Given this list of marker genes HSPG2, DPP3 (dipeptidyl peptidase 3), CREB3L2, EP300, CDKN2A, ADCY2, TXNRD2, GPX5, PARN, HSPE1, CRTC2, RPL22, LONP1, ABCF2, NUP85, SEH1L, EP400, ASNS, ETS1, LMNA, PRDX5, RHEB, MUL1, DNAJB1, EXOSC6, SCMH1, ELOC, BMI1, H1-4 (H1.4 linker histone, cluster member), FKBP4, PSMA3, MAPK11, TLR4, RRAGB, H3C2, RPS27, LAMTOR4, RPL21 (NCBI Gene Id 6144), COX6B2, MAPK3, AKT1S1, H2BC9, KICS2, PSMB4, RPL37A, GNG13, RPLP2, MIOS, E2F2, GPX2, CDKN1B, PKN2, EPO, ASF1A, CREB1, COX7A2, TUBA3C, PECAM1, PRDX6, CREB3L1, WIPI1, SZT2 (NCBI Gene Id 79597), CAPNS2, H4C5, GML, H2BC12L, PPP2R1A, CSNK2B, TATDN2, EPAS1, RPS25, DNAJA2, TXN2, ATF6, NRIP1, CRYAB, COX7C, SUZ12, NUP214, GRB10, PDIA5, ATP6V1A, RPS12 (NCBI Gene Id 6206), GSTP1, H2AB1, HBA2, NOX5, CAPNS1, ME1, GNG12, SMARCD3, CAPN2, ANAPC16, RPS6KA1, ATP6V0C, CASTOR1, POT1, COX5A, H3-4, RPL38, RPL6 (NCBI Gene Id 6128, ribosomal protein L6), MTOR, NUP42, PSMA7, CDH5 (cadherin 5), RPL4, PPP2R2A, TERF2IP, CDC26, MTF1, FLT4, EGLN3, H4C16, MAPKAPK3, PHC1, MRE11, MLST8, EDEM1, DCTN6, ETS2, SIN3B, DEDD2, PTK2, RPL28, RB1, NFYA, EXOSC5, ACTR10 (actin related protein 10), CDK2, SKP1, MT1M, MAPK7, ANAPC10, CHD9, HSF1, CLEC1B, CDKN1A, RPL15, HSPB2, FABP1, RPL31, YIF1A, TUBB2A, ABL1, ADCY7, GPX3, ATF4, NOTCH1, H2BC10, H2BC12, ANAPC7, BTRC, FOS, ATP6V1G1, ST13, UBE2E1, PIK3R2, NFKBIA, DYNC1I2, COX7A2L, VEGFA, ZBTB17, ADRM1, ATP6V1B1, CHAC1, NUP62, PSMC1, PPARGC1A, HDGF, H3C6, RPS9, PPP2CA, BAG3, FBXL17, COX4I2, KPTN, NCOR2, CACNB2, RPL8, DNAJA4, APOB, ATP6V1C1, DYNC1I1, CALM1, TRPV4, PDGFA, PSMB5, TUBA1C, PTGES3, EXTL1, EGF, GSTA3, PSMA2, ABCC3 (NCBI Gene Id 8714), H2AJ, PSMB6, PRKAR2B, RPL12, LAMTOR3, PPP1R15A (NCBI Gene Id 23645), RPS27A, H2AC20, RPL18A (ribosomal protein L18a), H2BC13, RPL26, CABIN1, SNCB, CSRP1, PPP2R1B, ARFGAP1, STAT1, PRKAR2A, H2BC15, CBX4, RAMP2, PPARA, RPS6KA3, GNG5, EHMT1, MAPK8, HSPB1, H2BC5, PIK3CD, ATP6V1E2, SOD1, H2AC19, HSPA1B, SERPINH1, H2BC7, AR, DCTN5, ADCY3, UFD1, MT1H, ITGB3, ITGAV (NCBI Gene Id 7449), DNAJC3, HSBP1, TGS1, PRKCI, DDX11, NUP188, P4HB, MT1A, PREB, MAP2K3, E2F1, ANAPC11, H4C9, CALR, TNRC6B, CITED2, RPS17, TRIB3, MT-CO1, CCS, EXTL3, H4C3, DCTN4, RPL17, HSPD1, MYC, HSPA1L, STOML2, STAT3, WDR59, H3-3B, SSR1, NCOA1, IKBKE, RPA2, EGLN1, CDKN2B, CDC23, DCSTAMP (NCBI Gene Id 81501), GNB5, NUP98, BAG1, CCNE2, RPL39, COX6B1, RPS7, NCOR1, AGO1, SAMTOR (NCBI Gene Id 154743), FLCN, HIGD1A, DYNLL1, H1-3 (NCBI Gene Id 3007), GSK3A, EXOSC2, SRPRB, RPL13A, H3C11, TALDO1, MIR24-2, MAPK14, PIK3CA, PSMC2, CCNA1, HSPA8, CACNG7, HSPA13, SERP1, IKBKB, BLVRB, H3C1, RPL14, RPS14, GPX6, H1-0, ADCY9, HSPA9, ERO1A, HMOX2, CSNK2A2, XBP1, SKP2, RANBP2, EIF2S2, PSMC4, ACTR1A, PIK3CB, TBL1XR1, DEFA5, HSPH1, KDELR3, HSPA6, NPRL2, ANAPC5, NRF1, RPLP1, RPL10A, RPS5, MBTPS2, MAPK1, TINF2, CEBPB, CREBBP, COX7B, ABCG2, APOA1, CREB3L3, GNGT1, HSP90AB1, PDIA6, TNFRSF21, HSPA14, NDC1, P2RY2, NOS3, TUBB4A, ATF3, DYNLL2, NUP50, H2AC7, CDKN2C, BACH1, TBL1X, NFYB, ACD, PSMB7, PRDX1, CACNA1H, CAMK2A, PRR5, HSPA5, ITGA5, MAP2K7, TXNIP, H3C4, H4C4, H4C15, ANAPC15, HMOX1, RPL36, ATP6V1F, NBN (NCBI Gene Id 4683), PGR, GNGT2, AMER1, RPL24, PTK6, NUP160, CUL7, SRXN1, HMGA2 (high mobility group AT-hook 2), PSMD12, AKT2, TPR, RPS23, WTIP, HTRA2 (HtrA serine peptidase 2), H2AC14, PRKCD, KAT5, SIRT3, TUBB2B, NOX4, H3C14, DDIT3, BCL2, PRKAR1A, H2BC21, SP1, UBB, TUBA1B, H2BC8, CXCL8, NUP43, FZR1, NUP133, LAMTOR1, NUP205, H4C11, TFDP1, MAPK10, IL6, RORA, RPS3, H2AC8, MAP2K6, PSMB2, SH3BP4, GSTA1, CCNE1, RPL36AL, HELZ2, RPS4X, ADM, PALB2, HBB, CDK6, RPLP0, NFE2L2, NR3C1, MT1X (NCBI Gene Id 82523), RPL13, RPS2, TERF1, BMAL1, SLC7A11, POM121C, MAP1LC3B, AKT1, RBX1, ERN1, H2AC4, TUBAL3, GNG3, ATF6B, H2BC1, RPS15, RPS3A, PRKACA, H3-3A, KDM6B, ABCC1 (ATP binding cassette subfamily C member 1 (ABCC1 blood group)), MAP2K4, COX6C, GNG7, H2BC11, RPS4Y1, GNG2, PSMD8, ATP6V0B, PDE4D, H4C6, TCIRG1, NFYC (NCBI Gene Id 54488), RPS11, UBE2D3, CACNB1, RNF2, CA9, RXRA, ATP6V0E1, ANXA2, DCP2, H3C13, H2BC17, ANAPC4, RPSA, PRKACG, IFNB1, ARNT, GCN1, ATP6V0D2, ID1, SIRT1, RING1, SRPRA, RRAGD, LY96, P2RX7, NUDT2, MT4 (NCBI Gene Id 84560), EIF2S3, H4C13, EGLN2, WDR24, ITGB1, TPP1, TUBB6 (tubulin beta 6 class V), RPS15A, BAG4, NPLOC4, TUBB8B, H3C3, PSMA4, DNAJB11, RPL7A, MAP4K4, HERPUD1, OMA1, MEF2D, VENTX, CEBPG, GCLM, H2BC14, VCL, H2BC3, ATF2, XPO1, MT-CO3 (NCBI Gene Id 4514), CDC16, SOD2, CDK4, SLC38A9 (solute carrier family 38 member 9), EXOSC3, PANX1, H1-1, ADCY8, USP46, SULT1A3, PSMB1, HSPA4, RPL9, CAMK2D, H4C2, H1-5, POM121, CCAR2, PRDX3, CARM1 (NCBI Gene Id 10498), GNB2, COX6A2, ATP6V1D, NUP35, EXOSC4, E2F3, PDPK1, CUL3, SIN3A, ITFG2, NDUFA4, RPL23 (ribosomal protein L23), H2BC6, H2AX, AKT3, RPS6 (NCBI Gene Id 92956), MAP3K5, ATM, AREG, DNAJC7, BLVRA, ERF (ETS2 repressor factor), H4C1, GSR, MAPKAP1, RPL19 (ribosomal protein L19), MAPKAPK5, RPL29, COX8A, PSMB3, NCOA6, TUBA8, GNAS, HSPA1A, TNRC6A, ATP6V1B2 (ATPase H+ transporting V1 subunit B2), TUBB4B, RPS10, UBE2D1, CAMK2G, GNAQ, TUBB3, CASTOR2, TUBB1, PRDX2, IMPACT, RPS27L, IGFBP7, PSMC6, PSMD1, H3C7, NR1D1 (NCBI Gene Id 9572), PGD, UBE2C, MT1E, IDH1, SESN2 (NCBI Gene Id 83667), ATF5, RPTOR, SLC46A1 (solute carrier family 46 member 1), EHMT2, H4C8, NFKB1, TUBA4B, UBE2S, UBA52, RPL27A, ANAPC1, TLN1, PIEZO1, MDM2, CAMK2B, H4C12, ADCY4, UBE2D2, TERF2, SEC31A, MT3, PSMD7, PHC2, RAI1, CDKN2D, FKBP14, RPL36A, HIF1AN, RRAGA, FKBP5, HIGD1C, RPL35A, PLA2G4B, UBC, MT1B, NUP155, CUL1, RPA1, CYBB, RBBP4 (RB binding protein 4, chromatin remodeling factor), EXOSC1 (NCBI Gene Id 51013), HSPA2, NUP153, MAPK9, WFS1, MED1, RBBP7, IL1A, MRPL18, NUP88, GCLC, NUP107, RPS21, NUP210, TUBA4A, PHB2, LMNB1, COX8C, SOD3, GJA1, GNB1, RPL22L1, CRTC1, DNAJB9, CREBRF, RPS18, ATR, CALCRL, PTPN1, NLRP3, CYBA, CTDSP2, HSPA12A, CYCS (NCBI Gene Id 54205), RPL35, EXTL2, MOV10, SQSTM1, ATP6V1E1, H2BC4, MYDGF, TP53, RPL41, EIF2S1, EEF1A1, UBN1, NPRL3, GNG8, NUP37, HSPB8, RPS19BP1 (ribosomal protein S19 binding protein 1), PSMC5, CLOCK, NCF1, IKBKG, RPS29, PRKACB, GNB4, EXOSC8, BAG2, ATP6V0D1, RPL27, UBXN7, CTNNB1, HM13, NUP93, PSMD2, EXOSC9, TRIM21, CCNA2 (NCBI Gene Id 890), PSMD13, RPL10L (ribosomal protein L10 like), CAPZA1, DNAJA1, RPS20, CACNB3 (NCBI Gene Id 784), HBA1, TUBB8, HIKESHI, CHUK, AGO4, RPL30, ADCY5, SPP1, PRKAR1B, CSNK2A1, FAU, CREB3, TUBA1A (NCBI Gene Id 95407), MAPKAPK2, RPS26, RPL7, STIP1, FOXO3, FNIP1, RRAGC, RLN1, COX5B, NCF2, IGFBP1 (insulin like growth factor binding protein 1), SEC13 (NCBI Gene Id 6396), KDR, COX6A1, HDAC3, DCTN1, NPAS2, ADD1, COL4A6, TNRC6C, CUL2, ATP6V1H, PGRMC2, DNAJB6, EIF2AK3, ADCY1, AQP8, COX4I1, RPS4Y2, CAPZA2, HIF3A, YWHAE, PSMD3, RPS6KA2, DNAJC2, RPL23A, RAE1, H4C14, ADCY6, DYNC1LI2, TXN, LAMTOR5, KHSRP, ATP6V0E2, CBX6, AAAS, FNIP2, DIS3, MT-CO2, FYN, TSPYL2 (TSPY like 2), CACNA2D1, H1-2, STAP2, KLHDC3, H3C15, NUP58, CDC27, YME1L1, TXNRD1, EIF2AK1, LIMD1, MBTPS1, CBX8, JUN, G6PD, CREB3L4, RPS8, VHL (von Hippel-Lindau tumor suppressor), MAFG, NUP54, AJUBA, MT1G, EIF2AK4, KEAP1, EXOSC7, MDM4, ALB, BCL2L1, RPL3L, RPL34, BAG5, MMP14, RPL32, LAMTOR2, NCOA2, HSP90AA1, CRTC3, NR3C2, RPL37, CXXC1, RPL11, GPX1, PSMC3, TUBA3D, H2AC6, HMGA1, HIRA, TKT, PSMD11, GOSR2, GNA11, HIF1A, ELOB, MT1F, ATP6V1G3, H3C12, NCF4, HYOU1, BRCA1, SYVN1, ESR1, GNG4 (G protein subunit gamma 4), TNIK, EED, GPX7, RPL5, SESN1, GSK3B, H2BC26, DYNC1H1 (NCBI Gene Id 992), PSMA5, SEM1, ACADVL, H2AZ2, AGO3, H3C10, HDAC6, RPL18, PSMD6, DCTN2, CCL2, ATP6V1C2, CAPZB, RPL3, PSMD14, VCP, FN1, PPP2R5B, RPS19, DCTN3, MT2A, DYNC1LI1, RPL10, RPS28, GFPT1, CAT, TFDP2, GNG11, RPS16, HSP90B1, DEPDC5, NQO1, GPX8, DELE1, COX7A1, RELA, EZH2, MEF2C (NCBI Gene Id 4208), PHC3 (NCBI Gene Id 80012), MINK1, H3C8, ATP7A, MIR24-1, YAP1, PRKAA2, GNG10, PSMA6, CRYBA4, ATOX1, RPL39L, CBX2, ATP6V1G2, RAD50, RPS24, MAFK, RPL26L1, ANAPC2, RPA3, RPS13, GNB3, RICTOR, HSPA12B, HSPA4L, PSMA1, TUBA3E, SHC1, CAPZA3, H2AC18, here is a description of the gene set: Human Gene Set: REACTOME_CELLULAR_RESPONSES_TO_STIMULI Cellular responses to stimuli species: Homo sapiens